Given this list of marker genes Rgs2, Slc6a20b, Slc6a9, Slc6a7, Slc6a5, Slc6a20a, Slc36a2, Slc6a14 (NCBI Gene Id 80646, solute carrier family 6 (neurotransmitter transporter), member 14), Rgs4, here is a description of the gene set: The directed movement of glycine from outside of a cell, across the plasma membrane and into the cytosol. species: Mus musculus Mouse Gene Set: GOBP_GLYCINE_IMPORT_ACROSS_PLASMA_MEMBRANE